Given this list of marker genes GTF2E2, MYB, IRF2, DYNLL1, CCND3, ATP2A3, ADA (NCBI Gene Id 100), CD79A, IL7R, ZNF22, MYL6B (myosin light chain 6B), TCF3, ACADM, SRP9, CBX1, STMN1, SMARCA4, TOP2B, RBBP4, NUP88, DHPS, MCM3, CYFIP2, PSMA6, here is a description of the gene set: Although cancer classification has improved over the past 30 years, there has been no general approach for identifying new cancer classes (class discovery) or for assigning tumors to known classes (class prediction). Here, a generic approach to cancer classification based on gene expression monitoring by DNA microarrays is described and applied to human acute leukemias as a test case. A class discovery procedure automatically discovered the distinction between acute myeloid leukemia (AML) and acute lymphoblastic leukemia (ALL) without previous knowledge of these classes. An automatically derived class predictor was able to determine the class of new leukemia cases. The results demonstrate the feasibility of cancer classification based solely on gene expression monitoring and suggest a general strategy for discovering and predicting cancer classes for other types of cancer, independent of previous biological knowledge. Human Gene Set: GOLUB_ALL_VS_AML_UP from publication Golub TR, Slonim DK, Tamayo P, Huard C, Gaasenbeek M, Mesirov JP, Coller H, Loh ML, Downing JR, Caligiuri MA, Bloomfield CD, Lander ES (PMID 10521349) Up-regulated genes highly correlated with acute lymphoblastic leukemia (ALL) vs acute myeloid leukemia (AML). studied in species Homo sapiens